The following is a description of a gene set: studied in species Homo sapiens Catalysis of the reaction: a 1-phosphatidyl-1D-myo-inositol 4-phosphate + ATP = a 1-phosphatidyl-1D-myo-inositol 3,4-bisphosphate + ADP + H+. Human Gene Set: GOMF_1_PHOSPHATIDYLINOSITOL_4_PHOSPHATE_3_KINASE_ACTIVITY, and this is the list of marker genes: PIK3CA, PIK3CG, PIK3C2A, PIK3CD, PIK3CB, PIK3C2G, PIK3C2B